The following is a description of a gene set: Enables the transfer of C4-dicarboxylate from one side of a membrane to the other. Mouse Gene Set: GOMF_C4_DICARBOXYLATE_TRANSMEMBRANE_TRANSPORTER_ACTIVITY species: Mus musculus, and this is the list of marker genes: Slc13a5, Slc1a5, Slc25a18, Slc1a6, Slc25a22, Ucp2, Slc25a12, Slc13a2, Slc25a13, Slc1a4, Slc16a1, Slc25a11, Slc1a1, Slc25a10, Slc13a3